The following is a description of a gene set: Up-regulated genes in MDA-MB-435 cells (breast cancer) undergoing G2/M arrest after treatment with 2-methoxyestradiol (2ME2). species: Homo sapiens 2-methoxyestradiol (2ME2), an estradiol metabolite with antiproliferative and antiangiogenic activities, is in phase I/II clinical trials for breast cancer. 2ME2 inhibits microtubule polymerization and causes cells to arrest in G2-M. The purpose of this study was to further elucidate the molecular mechanism of 2ME2. MDA-MB-435 breast cancer cells were treated with 2ME2 (2 micromol/L) or vehicle alone. RNA was extracted and genomic profiling was done using 22k Agilent microarrays. Expression Analysis Systematic Explorer was used to determine enrichment of Gene Ontology categories. Protein isolates were subjected to Western blot analysis. Protein synthesis was measured with amethionine pulse assay. An MDA-MB-435 cell line with two beta-tubulin mutations (2ME2R) was used to determine whether novel mechanisms were tubulin-dependent. Gene Ontology categories enriched include genes that regulate the mitotic spindle assembly checkpoint, apoptosis, and the cytosolic ribosome. The target of the mitotic spindle assembly checkpoint is the anaphase-promoting complex (APC). APC inhibition was confirmed by measuring protein levels of its targets securin and cyclin B1, which were increased in 2ME2-treated cells. Because gene expression in the cytosolic ribosome category was decreased, we evaluated whether 2ME2 decreases protein translation. This was confirmed with a pulse assay, which showed decreased isotope incorporation in 2ME2-treated cells, which was maintained in the tubulin-resistant 2ME2R cells. APC inhibition was not maintained in 2ME2R cells. 2ME2 induces tubulin-dependent cell cycle arrest through regulation of genes involved in the mitotic spindle assembly checkpoint, which results in inhibition of the APC and tubulin-independent inhibition of protein translation. from publication Bhati R, Gökmen-Polar Y, Sledge GW Jr, Fan C, Nakshatri H, Ketelsen D, Borchers CH, Dial MJ, Patterson C, Klauber-DeMore N (PMID 17234781) Human Gene Set: BHATI_G2M_ARREST_BY_2METHOXYESTRADIOL_UP, and this is the list of marker genes: EIF5A2, LRP3, H2AC8, NACC2, DKK1, NUF2, MED17, CCN1, SPC25, CALHM6, HSP90AA1 (NCBI Gene Id 89272), RAX2, TNPO1 (transportin 1), CEP43, PDGFC, FAP, IL24, PSMA3, IFNLR1, ALG13, NDC1, PCMT1, H1-2, ANKRD42-DT, CCNB1, RASIP1, PHIP, GGT6, NDUFAB1, GALNT2, PIF1, GNG11, TNFSF14 (TNF superfamily member 14), SCLY, CBX3, SPHK1, GP2, API5, GMNN (NCBI Gene Id 51053), TBX18, H3C8, PTBP2, PCNA, SMOX, FOS, POLR2A, IL12RB2, KYNU, GCLM, EBLN2, MIR22HG, AURKA, MPP4, LIMK1, NRAS, TUBB6, NLRP2, RAMP1, HCK, DNAL1, CORO1C, PBK, WWTR1, MYBL2, SOD2, UBR7, IER3, EIF2S1 (eukaryotic translation initiation factor 2 subunit alpha), TACSTD2, SND1-IT1, CTNNAL1, ZSCAN30, YIF1B, TEP1, HACD3, PDZD7, SNRPA1, PSMA2, MAD2L1, FAM3C, PRAC1, CERK, BUB1, PPP1R12B, FAM215B, TMC8, PDE4C, CDC6, LSM6, ILDR1 (immunoglobulin like domain containing receptor 1), PCYOX1, ASPM, CALR, NEK2, CDC20, NEDD4L, BMS1P1, ANKK1, ATL3 (atlastin GTPase 3), CTPS1, RAB27A, PNN, ERC2-IT1, GALNT3, MAPK1, ELOA, NDUFA9, RABGEF1, EGR1, TFRC (NCBI Gene Id 7037), OGFRL1, ASRGL1, PLEKHB2, TTC39A, PURB, STAG3L1, HSPA5, PTTG2, SPARC, SPCS3, DLGAP5, ANXA1